The following is a description of a gene set: Oncogenic MAPK signaling Human Gene Set: REACTOME_ONCOGENIC_MAPK_SIGNALING species: Homo sapiens, and this is the list of marker genes: CALM1, RAF1, NF1, SPRED1, MAPK3, MRAS, DUSP10, SRC, JAK2, TLN1, LMNA, YWHAB, KSR2, BRAP, MAPK1, PAPSS1, DUSP9, AGGF1, AGK, RAP1A, FAM131B, SPRED2, DUSP7, ACTB, KSR1, PHB1, FGA, RAP1B, HRAS, KIAA1549, BRAF, MARK3, KRAS, PPP1CC, MPRIP, DUSP8, AGTRAP, CAMK2A, QKI, IQGAP1, DUSP6, CNKSR2, CNKSR1, MAP2K1, SPRED3, TENT4A, SND1, ITGB3, PEBP1, VCL, CSK, FN1 (NCBI Gene Id 2335), BCL2L11, CAMK2B, ESRP1, ARRB2, NRAS, ITGA2B, AKAP9, ZC3HAV1, ARAF, FGG, CAMK2G, PPP1CB, TRIM24, SHOC2 (NCBI Gene Id 8036), FAM114A2, CLCN6, ATG7, KDM7A, MAP2K2, ACTG1, AP3B1, MAP3K11, TRAK1 (NCBI Gene Id 22906), DUSP16, APBB1IP, CAMK2D, VWF, ARRB1, FXR1, FGB